Given this list of marker genes Kras, Hey2, Fam135a, Actmap, Schip1, Whrn, Ncam2, Zdhhc20, Gucy1a2, Kansl1, Rnmt, Asap2, Dnaaf11 (NCBI Gene Id 54562), Ostn, Dclk1, Zfp397, Smco3, Wdr77, Dnajb7, Rps6kb1, Lrp2, Thoc2, Rbm46, Impact, Mat1a, Rabgap1l, Slc16a7, Nufip2, Mtf2, Prkce, Dsc2, Syt13, Sacm1l, Mettl15, Slc7a2, Iqschfp, Mrpl57, Csf1r, Lrrn4cl, Nfkbiz, Cd1d1, Lmo4, Pls1, Zfp189, Csmd3, Pdhx, Ythdf3, Rcor2, Cdh9, Plpp3, Adam23, Syt1, G2e3, Rab10, Ebag9, Scimp, Htr5a, Pigw, Nexmif, Supt20, Corin, Fam120a, Bnip3l, Tmf1, Vmn1r148, Clint1, here is a description of the gene set: Genes predicted to be targets of miRBase v22 microRNA mmu_miR_409_3p in miRDB v6.0 with MirTarget v4 prediction scores > 80 (high confidence targets). species: Mus musculus from publication Chen Y, Wang X (PMID 31504780) Mouse Gene Set: MIR_409_3P